The following is a description of a gene set: A developmental defect resulting in the congenital absence of skin on the scalp. studied in species Homo sapiens Human Gene Set: HP_APLASIA_CUTIS_CONGENITA_OF_SCALP Aplasia cutis congenita of scalp, and this is the list of marker genes: MCTP2, UBR1, NSD2, FOSL2, DLL4, CPLX1, ITGB4, CDH1, ALG9, MSX2, UBA2, BMS1, ARHGAP31 (Rho GTPase activating protein 31), NELFA, ITGA6, FGFRL1, PIGG, LETM1, PLEC, ALX4, CTBP1